Given this list of marker genes ACTL6B, BICRA, BCL7A, SMARCD1, SMARCC1, SS18, SMARCA4, ACTB, ACTL6A, BCL7C, BICRAL, BCL7B, SMARCA2, BRD9, here is a description of the gene set: Human Gene Set: GOCC_GBAF_COMPLEX studied in species Homo sapiens A SWI/SNF subcomplex that incorporates two mutually exclusive paralogs, GLTSCR1 (glioma tumor suppressor candidate region gene 1) or GLTSCR1L (GLTSCR1-like), BRD9 (bromodomain-containing 9) and the BAF subunits BAF155, BAF60, SS18, BAF53a, and BRG1/BRM.